Given this list of marker genes Bcl2, C5ar1, Mapk10 (NCBI Gene Id 319641), C3ar1, Bag4, C4b, Traf3, Cdkn1c, Map3k9, Nfkb1, C1qb, Tdp2, Casp9, Nfkbie, Map2k4, Traf2, Tnfrsf1b, Cdc42, Apaf1, Cycs, Gadd45a, Tnf, C2, Bad, Hc, C1ra, Traf1, Cyct, Cdkn1a, Tnk2, Map3k1, C1s1, Pcna, C1qc, Casp3, Cdkn1b, Mapk13, C1qa (NCBI Gene Id 12259), Cr2, Traf6, here is a description of the gene set: Oxidative damage response Mouse Gene Set: WP_OXIDATIVE_DAMAGE_RESPONSE species: Mus musculus